The following is a description of a gene set: species: Homo sapiens Genes predicted to be targets of miRBase v22 microRNA hsa-miR-136-3p in miRDB v6.0 with MirTarget v4 prediction scores > 80 (high confidence targets). Human Gene Set: MIR136_3P from publication Chen Y, Wang X (PMID 31504780), and this is the list of marker genes: SHROOM2, TGFB2, MEPE, SNTB2, VASN, PHF21B, TOR1AIP2, TAB2, SCP2D1